The following is a description of a gene set: species: Homo sapiens Human Gene Set: TURASHVILI_BREAST_CARCINOMA_DUCTAL_VS_LOBULAR_DN from publication Turashvili G, Bouchal J, Baumforth K, Wei W, Dziechciarkova M, Ehrmann J, Klein J, Fridman E, Skarda J, Srovnal J, Hajduch M, Murray P, Kolar Z (PMID 17389037) BACKGROUND: Invasive ductal and lobular carcinomas (IDC and ILC) are the most common histological types of breast cancer. Clinical follow-up data and metastatic patterns suggest that the development and progression of these tumors are different. The aim of our study was to identify gene expression profiles of IDC and ILC in relation to normal breast epithelial cells. METHODS: We examined 30 samples (normal ductal and lobular cells from 10 patients, IDC cells from 5 patients, ILC cells from 5 patients) microdissected from cryosections of ten mastectomy specimens from postmenopausal patients. Fifty nanograms of total RNA were amplified and labeled by PCR and in vitro transcription. Samples were analysed upon Affymetrix U133 Plus 2.0 Arrays. The expression of seven differentially expressed genes (CDH1, EMP1, DDR1, DVL1, KRT5, KRT6, KRT17) was verified by immunohistochemistry on tissue microarrays. Expression of ASPN mRNA was validated by in situ hybridization on frozen sections, and CTHRC1, ASPN and COL3A1 were tested by PCR. RESULTS: Using GCOS pairwise comparison algorithm and rank products we have identified 84 named genes common to ILC versus normal cell types, 74 named genes common to IDC versus normal cell types, 78 named genes differentially expressed between normal ductal and lobular cells, and 28 named genes between IDC and ILC. Genes distinguishing between IDC and ILC are involved in epithelial-mesenchymal transition, TGF-beta and Wnt signaling. These changes were present in both tumor types but appeared to be more prominent in ILC. Immunohistochemistry for several novel markers (EMP1, DVL1, DDR1) distinguished large sets of IDC from ILC. CONCLUSION: IDC and ILC can be differentiated both at the gene and protein levels. In this study we report two candidate genes, asporin (ASPN) and collagen triple helix repeat containing 1 (CTHRC1) which might be significant in breast carcinogenesis. Besides E-cadherin, the proteins validated on tissue microarrays (EMP1, DVL1, DDR1) may represent novel immunohistochemical markers helpful in distinguishing between IDC and ILC. Further studies with larger sets of patients are needed to verify the gene expression profiles of various histological types of breast cancer in order to determine molecular subclassifications, prognosis and the optimum treatment strategies. Genes down-regulated in ductal vs lobular carcinoma breast tumor cells., and this is the list of marker genes: NEAT1, VTCN1, SEC24A (SEC24 homolog A, COPII coat complex component), ASPN, FAM200C, MID1, MAOB